Given this list of marker genes H2AB1, H2AC6, MYO1C, H4C8, H3C11, DDX21, POLR2H, H4C13, H2AC4, H2BC8, H2AX, H2AC8, TBP, ACTB, H2BC12L, H3C3, POLR1C, H4C9, SMARCA5, POLR2F, MYBBP1A, H2BC14, H3C14 (H3 clustered histone 14), POLR1G (RNA polymerase I subunit G), POLR2E, H2BC1, H2BC12, TAF1D (NCBI Gene Id 79101), H2AZ2, H2BC26, H4C2, H4C4, TAF1A, H3-3B, H4C11, H4C6, KAT2B, KAT2A, H4C15, H2BC5, H3C6, H3C15, H2BC7, POLR2L, ERCC6, POLR1F, POLR2K, H4C1, H3C8, H2BC10, H3C7, H3C2, H2BC9, H2AJ, POLR1D, POLR1H, H2BC15, POLR1A, H4C12, EP300, H4C5 (H4 clustered histone 5), H2AC7, H2AC19, TAF1C, H3C4, POLR1E, H3C12, H2AC14, H2BC11, TAF1B, H2BC3 (NCBI Gene Id 3018), H3-3A, H4C16, H2BC21, H3C10, GSK3B (NCBI Gene Id 2932), H3C13 (H3 clustered histone 13), H4C3, BAZ1B, H2AC20, SF3B1, H2BC13, POLR1B, H2AC18 (NCBI Gene Id 8337), H4C14, H2BC17 (H2B clustered histone 17), H2BC4, DEK, H3C1, H2BC6, here is a description of the gene set: Human Gene Set: REACTOME_B_WICH_COMPLEX_POSITIVELY_REGULATES_RRNA_EXPRESSION B-WICH complex positively regulates rRNA expression species: Homo sapiens